The following is a description of a gene set: human blood monocytes were isolated, activated and harvested at several timepoints In this study, we identified genes that were differentially expressed in human monocytes activated with eiter NOD2L and/or TLR2/1L. studied in species Homo sapiens Genes up-regulated in monocytes (6h): untreated versus M. tuberculosis 19 kDa lipopeptide. from publication Schenk M, Krutzik SR, Sieling PA, Lee DJ, Teles RM, Ochoa MT, Komisopoulou E, Sarno EN, Rea TH, Graeber TG, Kim S, Cheng G, Modlin RL (PMID 22447076) Human Gene Set: GSE34156_UNTREATED_VS_6H_TLR1_TLR2_LIGAND_TREATED_MONOCYTE_UP, and this is the list of marker genes: RBM47, NDUFB4, CSF1R, FCGR2A, ALDH3B1, FPR1, S100Z, VPS33B, IRF5, MANBAL, NUDT6, SMIM3, HBEGF, GK3, MAFB, DOCK4, SIRPA, ASPH, IFI30, TSC22D1, METTL22, LILRB4, VCAN, GCA, RAB34, GLUL, PLCXD3, FLT3, CNPY3, HMOX1, KLK1, PTAFR, GPX1, HCK, NID1, WDR41, ADAM28, MPP1, AOAH, KYNU, NCF2, CYBB, ABCA1, TNS3, CHST15, MYOF, GASK1B, CTSZ, TALDO1, PTPN6, GPAT3, C15orf48, SLC43A2, ATP6V0B, CYP27A1, ATP6V1C1, TCF4, TPP1, DMXL2, RAC1, RP2, SLC37A2, MGST1, HSD17B14, TMEM51 (transmembrane protein 51), HCAR3, NCF4, PSAP, BRI3, ZNF385A, UNC45B, ZBED5, CARD19, MIR3142HG, BCAT1, CREG1, LILRA6, PILRA, LHFPL2, TFEC, SRC, CSF2RB, GSTO1, GRTP1, CXCL16, CTSLP8, ASAH1, CSF2RA, TMCC3, LGALS1, VRK2, FCGRT, MAP4K3 (NCBI Gene Id 8491), FCGR2C, P2RX4, SLC8A1-AS1, CD86, CLIC4, IDH2, ADGRE2 (adhesion G protein-coupled receptor E2), ARMCX1, ACOT9, C1orf226, NOP10, LMO2, NRP2, MNDA, EPB41L3, IFNA14, MSR1, ADM, KCNJ2 (NCBI Gene Id 3759), PRG2, SEZ6L, HPSE, SLC11A1, LILRB2, DAPP1, WARS1, LRRC49, DSE, GRN, STK38L, SESTD1, ALPP, SVBP, GSDME, GJA5, SLC25A37, ALAS1, FPR2, C6orf62, WDFY3, VPS37C, CD14, HLA-DRB4, PPARG, CACHD1, ATP6V1B2, DOK3, PSTPIP2, STEAP4, PLXNB2, IGSF6, LIN7A, VEGFA, GM2A, RHOU, GK, LGALS3, SRA1, OSCAR, UBE2Z (ubiquitin conjugating enzyme E2 Z), NPC2, AATK, TMEM127, CXCL1, TGFBI, TREML5P, FTL, ARHGEF2, FAM20C, SULF2, GS1-279B7.1 (microtubule associated protein 1 light chain 3 beta pseudogene), ADAM9, TMEM170B (transmembrane protein 170B), MFSD1, HS3ST3B1, CD63, DIP2B, LIFR, GNB4 (NCBI Gene Id 59345), PSMB1, MPEG1, SLC16A6, RAB31, TLR2, RAB7A, HLA-DOB, ANPEP, RPS6KA4, RAD51C, RAB20, CD300LF, PLAU, CD163, NCOA4, LILRB1, IL13RA1, NADK, LGALS2, CORO1C, THBD (NCBI Gene Id 7056), LILRB3, LY96, ANXA5, PMP22